The following is a description of a gene set: species: Homo sapiens Human Gene Set: LEF1_Q6 Genes having at least one occurrence of the motif SWWCAAAGGG in the regions spanning 4 kb centered on their transcription starting sites. This matches the LEF1, TCF1 transcription factor binding site V$LEF1_Q6 (v7.4 TRANSFAC)., and this is the list of marker genes: EDN3, HOXD10 (NCBI Gene Id 3236), LPCAT3, IGF1R, HOXB4, GPC4, SLC7A8, OARD1, LHX4, LRRN1, HS6ST1, RNF19B, CPNE1, GAP43, ACVR1B (NCBI Gene Id 93351), ZMAT4, ODF2, DCX, LINC03124, CDK6, CGN, ZFAND5, PRDM13, NRCAM, HOXD9, EBF2, BMP7, TFCP2, FOXA1, PIM2, GCA, DACH1, MMP21 (matrix metallopeptidase 21), INSM1, HOXD3, CLDN4, ARRDC3, ROBO4, CCL25, STEAP1, BCAR3, TUBB4A, HMGN5, ZIC4, MYCL, SIX1, RBMX, CHRNA9, ABHD15, LRP8, TCF7L2, CERS1, BMI1, PANK3, SIX4, SLCO5A1, NKD1, DPYSL3, IRS4, SNX17, KLF3-AS1, MOSMO, SRRM4, SCRT2, SMARCC1, EDA, ABR, LINC01138, FNBP1L, KRT32, NR6A1, MYL6B, EIF4A2, SP8, SLC17A6, EFNA1 (ephrin A1), PARP8, PCBP4, BAZ1A, CDX1, ABL1, AFF3, KCNJ13, ELF5, ARMC12, FST, DPYSL4, HR, CNTLN, HECTD1, UHRF1, SOX11, SLC26A9, THSD1, LHX9, SETD2, ASCL4, IVNS1ABP, EYA3, NARF (NCBI Gene Id 26502), NFATC4, TNFRSF19, HSD11B1, HEPACAM (hepatic and glial cell adhesion molecule), ARID1A, EYA2, REM2, SEMA4C (semaphorin 4C), KDM6A, FRMD6, EPHB3, MAP2K6, ABCD2, ZNF184, KIF5A, GDF1, KLF3, CASKIN2, TP53I13, CDK5R1 (cyclin dependent kinase 5 regulatory subunit 1), CHD2, TRPM1, ZNF516-DT, CLASP1, ZFHX3, TLNRD1, ELAVL2, BASP1, CDC14A, CCM2L, NFYA, KCND2, SUOX, DHX40, SLC17A2, HOXB7, NHLH2, ZBTB45, EFNA4, SERTAD4, CHN2, AIF1L, TSHZ2, ARHGAP20, STEAP1B (STEAP family member 1B), UBE2E4P, HOXA10, SDC1, SOX5, GABRB2, PTPRJ, PDE4D, CACNA2D1, SOX14, B3GNT5, TUBA1A, TGIF2, PTP4A1, SARM1, HOXD12, OTX2, LIFR, RNF44, ZNF775, SORBS1, VWA2, KCNH8, MEX3B, KATNAL1, FBXW4, TBXT, DGKA, PCBP1, NRP2, SYNCRIP, SULT2A1, ZNF703, MLLT6, WEE1, PAK1, WNT3, CNKSR2, IGDCC3, MORC3, FGF17, MARCKSL1, WNT6, FOXP2, MPZL1, RPL23A, ABHD2, SH3BGRL, SH3BP5, PIM1, CRIP2, KLHL5, MYH4, DSG4, DMXL1, SESN3, PHC1, PYM1, CUTA, CNOT7, MPPED2, NEUROD4, ARIH1, SPRY4, ABCD1, SEZ6, KHDRBS1, COL18A1, BCL7C, RGS3, MCF2L, GABRG2, ZNF532, PREX2, LINC00670, SLC25A28, CORO1C, SHF, TNXB, ELK3, CCNL2, ETV6, SYT11, EIF2B4, TSEN54, HOXC11, ADAM19, DCLK2, ANKRD28, VPS37A, WBP1L, RPP21, FGF10 (fibroblast growth factor 10), DHX9, PLSCR3, KCTD4, ZBTB18, PACSIN3, CA14, AGO1, MAFB, HIVEP1, ASAP2, OAZ2, DQX1, TMUB2, JUND, NDC1, DSG3, SHC3, PAX3, HOXC10, BAHD1, COL15A1, DOCK3, PRRX1, TCF7, MAP3K11, MIDEAS, HABP2, SLC22A8, LMO3, TGIF1